The following is a description of a gene set: Mouse Gene Set: GOBP_ISOTYPE_SWITCHING_TO_IGG_ISOTYPES The switching of activated B cells from IgM biosynthesis to biosynthesis of an IgG isotype, accomplished through a recombination process involving an intrachromosomal deletion between switch regions that reside 5' of the IgM and one of the IgG constant region gene segments in the immunoglobulin heavy chain locus. studied in species Mus musculus, and this is the list of marker genes: Foxp3, Ptprc, Atad5, Ndfip1, Cd40, Ifng (NCBI Gene Id 15978), Tbx21, Il2, Slc15a4 (solute carrier family 15, member 4), BC037156, Pms2, Pagr1a, Paxip1, Hspd1, Cd28, Msh2, Mlh1, Il4, Il27ra